Given this list of marker genes Col8a2, Col11a2, Col19a1, Pcolce2, Col22a1, Col4a1, Col18a1, Col4a4, P3h2, Col28a1, Colgalt2, Colgalt1, Tll1, Col9a1, Col9a2, Col5a2, Col4a5, Col6a2, Col4a2, Col6a1, Col26a1, Col6a3, Serpinh1, Col4a3, Adamts2, Col6a6, Pcolce, P3h3, Col12a1, P4ha3, Bmp1, Col14a1, Col8a1, Col3a1, Plod1, Tll2, Adamts14, Col7a1, Col5a1, P4ha2, Col1a1, Plod3, Col6a5, Col10a1, Col5a3, Col25a1, Col15a1, Col16a1 (collagen, type XVI, alpha 1), Plod2 (NCBI Gene Id 26432, procollagen lysine, 2-oxoglutarate 5-dioxygenase 2), Col20a1, Col13a1 (collagen, type XIII, alpha 1), Adamts3, Col1a2, Col9a3, Col4a6, P4ha1, Col2a1, Col11a1, Col23a1, Col17a1, P4hb, here is a description of the gene set: species: Mus musculus Collagen biosynthesis and modifying enzymes Mouse Gene Set: REACTOME_COLLAGEN_BIOSYNTHESIS_AND_MODIFYING_ENZYMES